The following is a description of a gene set: from publication Tabula Muris Consortium (PMID 32669714) species: Mus musculus Mouse Gene Set: TABULA_MURIS_SENIS_SPLEEN_MATURE_NK_T_CELL_AGEING, and this is the list of marker genes: Txndc5, Rpl35, Bex3, Plek, Rpl37, Rps10, Anxa2, Rps19, Ahnak, Crip1, Rps16, Rplp1, Rpl39, Rpl36a, Rsrp1, Rps12, Thap3, Nme2, Rpl41, Cd8b1, Krtcap2, S100a8, S100a9, Rps4x, Fyn, Micos13, Rpl22, Rpl27a, Zfas1, Rps24, Gtf2i, Gzmm, Jchain, Rps27 (ribosomal protein S27), Cdk2ap2, Rplp2, Bcl2, Rps20, Rpl35a, Rps13, Rps15a-ps6, S100a13, Lime1, Rpsa, Rack1 (receptor for activated C kinase 1), Rps23, Tox (NCBI Gene Id 76569), Reep5, S100a6, Romo1, Rpl38, Rpl31, Rpl5, Runx3, Ctla2a, Gpr183, Bola2, Vmp1, Hspe1, Rps21, Rpl14, Rpl36, Dpm3, Rps15a-ps4, H2aj, H2az1, Rpl31-ps12, Rps5, Ccr5, Klk8, Ccl4, Rbm3, Cst7 (cystatin F (leukocystatin)), Rplp0, Rpl6, Snrpg, Serpina3g, Eef1g, Slc25a4, Mrpl52, Lpin1, Ly6a, Rpl12, Rps28 (ribosomal protein S28), Gzmk (NCBI Gene Id 14945), Samd3, Rps15a, Emp3, Mif, Rps18, Klrk1, Rps29, Rps2, Rps26, Fau, Snhg8, Ms4a4c, Eif3i, Rpl23a, Rpl22l1, Ms4a6b (NCBI Gene Id 69774), Cd8a, Rps25, Rpl17, Rpl23, Vim (vimentin), Rpl32, Thy1, Ly6c2 (NCBI Gene Id 100093633), Psmb9, Gpr18, Ccl5, Rps8, Nkg7, Gstp3, Klf2, Gas5, Gng2 (guanine nucleotide binding protein (G protein), gamma 2), Eomes, Fcgrt, Rpl37a, Nsa2, Lgals1